Given this list of marker genes Pvr, Klrk1, Nectin2, Crtam, Il12b, Il12a, Cd160, Cd226, here is a description of the gene set: species: Mus musculus Any process that activates or increases the frequency, rate, or extent of natural killer cell mediated immune response to a tumor cell. Mouse Gene Set: GOBP_POSITIVE_REGULATION_OF_NATURAL_KILLER_CELL_MEDIATED_IMMUNE_RESPONSE_TO_TUMOR_CELL